The following is a description of a gene set: Human Gene Set: HP_NYCTALOPIA studied in species Homo sapiens Inability to see well at night or in poor light. Nyctalopia, and this is the list of marker genes: NMNAT1, DHX38, KIF3B, SLC24A1, CNGB1, AHR, IDH3B (NCBI Gene Id 3420, isocitrate dehydrogenase (NAD(+)) 3 non-catalytic subunit beta), OAT, TRIM32, ZEB1, ARL3, SEMA4A, RNU4ATAC, SNRNP200, ABCA4, SLC4A11, MVK, POC1B, BBS12, MKS1, ARSG, ATF6, CACNA1F, ESPN, BBS2, GUCA1A (NCBI Gene Id 387091), TTC8, ADAM9, GNAT1, BBS10, PRPF31, PEX5, PROM1, RP1L1, RAX2, AGBL1, BBS7, PEX16, LCA5, TRPM1, CERKL (ceramide kinase like), USH1C, CEP78, TRAPPC9 (trafficking protein particle complex subunit 9), HKDC1, CACNA2D4 (NCBI Gene Id 93589), VWA8, BBS4, RPGR, CRB1, PEX6, GRK1, RHO, FGFR2, CEP290, HARS1, MYO7A, PEX7, IDH3A, CNGA3, CHM, PRPF6, RIMS1, ADGRV1, HADHA, PDE6B, KIAA1549, PDE6G, MKKS, LZTFL1, RPE65, PHYH, RBP4, PRPF8, DHDDS (NCBI Gene Id 79947), RPGRIP1, CWC27, KLHL7, OPN1LW, CIB2, FLVCR1, RDH12, CA4, NYX, RS1, PDZD7, PCARE, TCF4, ARHGEF18, LRAT, YARS1, RLBP1, MFN2, CCDC28B, RP9, ITM2B, PITPNM3, USH1G, NEK2, GRM6, BBS9, WHRN, PEX2, IFT172, DRAM2, RP1, IMPDH1, C1QTNF5, MTTP, PEX14, ARL2BP, ZNF408 (NCBI Gene Id 79797), WDPCP, MAK, IFT43, REEP6, HGSNAT, CEP19, TIMP3, AGBL5, GGCX, PEX11B, CNGA1, FAM161A, IMPG1, CNNM4, USH2A, NPHP1, CLCC1, CYP4V2, IFT88, TULP1, SAG, CDHR1, COG4, POU3F4, GUCA1B, INPP5E, BBIP1, TUB, TTPA, CFAP418, PEX10, GNB3, TRNT1, PDE6H, RAB28, MERTK, ACBD6, RDH5, PEX26, POMGNT1, NR2E3, VPS13B, RP2, ZPR1, AIPL1, CABP4, BBS5, PEX3, FSCN2, PRPH2, PEX1, PEX13, CFAP410, OPN1MW, ELOVL4, IFT140, ARL6, CRX, CNGB3, HSD3B7, PEX12, SLC7A14, LRIT3, SDCCAG8, RGR, AHI1, MFRP, RBP3, TTLL5, PCDH15, CC2D2A, EYS, GUCY2D, WDR19, HK1, GNS, PRPF3, SCAPER, GPR179, PLA2G5, IMPG2, IFT74, SCLT1, RDH11, MMP19, MT-TS2 (mitochondrially encoded tRNA-Ser (AGU/C) 2), MYO6, NRL, PEX19, TLCD3B, SPATA7, UNC119, PDE6A, OFD1, KCNV2, EXOSC2, ROM1, DPAGT1, COL8A2, IFT27, CLRN1, KIZ, BBS1, CDH23, PRPF4, BEST1, IDS, STIM1, ZNF513 (NCBI Gene Id 130557), PRCD, TOPORS, KCNJ13, CLEC3B